The following is a description of a gene set: Mouse Gene Set: GOBP_GAMMA_AMINOBUTYRIC_ACID_BIOSYNTHETIC_PROCESS The chemical reactions and pathways resulting in the formation of gamma-aminobutyric acid (GABA, 4-aminobutyrate), an amino acid which acts as a neurotransmitter in some organisms. species: Mus musculus, and this is the list of marker genes: Aldh1a1, Slc1a3, Slc38a1, Gad1, Abat, Gad2